Given this list of marker genes Appl1, Cdh3, Mfsd12 (NCBI Gene Id 73822), Rab38, Gipc1, Zeb2, a, Ctns, Slc7a11, Rapgef2, Pmel, Atp7a, Wnt5a, Slc24a5, Opn3, Tyrp1, here is a description of the gene set: studied in species Mus musculus Mouse Gene Set: GOBP_REGULATION_OF_SECONDARY_METABOLIC_PROCESS Any process that modulates the frequency, rate or extent of secondary metabolism, the chemical reactions and pathways involving compounds that are not necessarily required for growth and maintenance of cells, and are often unique to a taxon.